The following is a description of a gene set: Genes up-regulated in comparison of dendritic cells (DC) stimulated with CpG DNA (TLR9 agonist) at 1 h versus DC cells stimulated with Gardiquimod (TLR7 agonist) at 1 h. mouse primary BMDCs were stimulated with tlr ligands and gene expression changes were profiled on Affymetrix arrays from publication Amit I, Garber M, Chevrier N, Leite AP, Donner Y, Eisenhaure T, Guttman M, Grenier JK, Li W, Zuk O, Schubert LA, Birditt B, Shay T, Goren A, Zhang X, Smith Z, Deering R, McDonald RC, Cabili M, Bernstein BE, Rinn JL, Meissner A, Root DE, Hacohen N, Regev A (PMID 19729616) Human Gene Set: GSE17721_CPG_VS_GARDIQUIMOD_1H_BMDC_UP species: Homo sapiens, and this is the list of marker genes: ANXA5, UGGT2 (NCBI Gene Id 80239), IRF8, PUS10, TBC1D8, DYRK1B, IKZF2, ELK3, ADAM33, ADH1C, ENPP5, APOM, TSPO2, HCFC1R1, CYTH1, MRPS9, TRIM13, DAPP1, ADHFE1, SLC25A17, SKIL, FAS, ST8SIA4, INTS6, RPS21, SRGN, TCF4, CWC15, CD274, ETV6, PGD, LZTFL1, ITGB3, SMC5, SLC41A1, TSPAN13 (tetraspanin 13), CACNB3, MRNIP, MMP15, CNGA1, HPD, CLASP1, SERTAD2, TELO2, RSPH6A, ARHGEF2, IL17RA, TBK1, FBXO33, TBC1D1, TMEM243, ADAMTS4, SENP1, KIF1B, L1CAM, FKBPL, HAAO, MYH9, TMEM260 (NCBI Gene Id 54916), SOWAHC, TAX1BP3, SPOCK3, SPINK4, CHRDL2, SEC22A, KCNJ11, OSTF1, ITPR2, PUM2, DMTN, TFEC, CHRD, RSPO1, RBM7, BICC1, EZH2, TNIP1, TCP10L (NCBI Gene Id 55264), BTG4, RFFL, PPP4R2, WSB1, PRR14, ARID1A, F11R, MAP3K8, KCTD10, CFB, BIRC2, DDX46, ASL, DUOXA2, MAP3K1, EIF1, FAH, SLC41A2, TTYH2, GGCX, IFT140, PLA2G6, SFXN3, ASPSCR1, VPS11, DLX1 (NCBI Gene Id 1745), DGAT2, CACNG1, PTGR1, APOB, PCDH15, ADD2, CMC2, TSC22D1, HEXD (hexosaminidase D), PLAT, CORT, TRPM5, PTRHD1, SUPT6H, SEMA5B, MYL2, SFI1, SRI, SGMS1, BCL2L2, SMAD7, IL15RA, FPR1, BPIFB1, OTUD7A, NDRG1 (NCBI Gene Id 7998), GJB3, JUN, PRCP, ITIH3, PDCD10, APBB3, RGS2, DBH, CTSS, SPSB2, CD200 (CD200 molecule), SLC44A1, PIP5K1A, LTC4S, CHKA, DTNB, THAP2, TENT2, SERPINF2, TTC39C, LDLRAD4, SCARA3, RANBP10, MDM2, PRICKLE1, CCR7, ATXN2, CYP26A1, KCNS2, GJB6, TBC1D15, SLC15A2, SLC25A25 (solute carrier family 25 member 25), FAM89A, FBXL8, PSMG4, LIN9, RNPC3, BCAS3, RAP2B, ANKZF1, BRD2, PCDHB13, KPNA4, KLHL13, ACSS2, NUP62, GJA1, GTF2B, WDR6, BTG1, DSCAML1, PSMC1, SPRYD7, GEM, C6orf58, SPAG7, SLC32A1, MYCT1, NXF1, PHF7, ROBO1 (roundabout guidance receptor 1), PORCN (NCBI Gene Id 65017), GPR83, MXRA8, ARX, DCBLD2 (discoidin, CUB and LCCL domain containing 2), GYPC, BRWD1, DOK3